The following is a description of a gene set: Human Gene Set: chr9p23 studied in species Homo sapiens, and this is the list of marker genes: ENSG00000303032, ENSG00000270372, IMP3P1, AKAP8P1, LINC01235, RN7SL5P, RN7SL849P, MPDZ, ENSG00000230920, JKAMPP1, RPS26P3, ENSG00000224935, PRDX1P1, LINC00583, LURAP1L-AS1, RPL3P11, PTPRD, PTPRD-DT, ATP5PDP3 (NCBI Gene Id 138864), PES1P2, TYRP1, LURAP1L, RNU2-47P